Given this list of marker genes Hdac7, Hdac5, Hdac1, Hdac11, Hdac8, Hdac6, Hdac2, Sirt1, Hdac3, Hdac4, here is a description of the gene set: studied in species Mus musculus Mouse Gene Set: GOMF_HISTONE_H4K12_DEACETYLASE_ACTIVITY_HYDROLYTIC_MECHANISM Catalysis of the reaction: histone H4 N6-acetyl-L-lysine (position 12) + H2O = histone H4 L-lysine (position 12) + acetate. This reaction represents the removal of an acetyl group from lysine at position 12 of the histone H4 protein.